Given this list of marker genes SOS1, RMI1, NHS, PICALM, IGF2BP3, ARMCX2, FOXA2, FIZ1, PRICKLE1, IRX5, UBC, SPRED2, SF1, ZFP91, SRSF3, NIPBL, JARID2, ACLY, OTX2, AP3D1, YWHAE, DDX6, KDM3A, PTMA, C2CD5, RBM39, GNG11, DHX15, BCL11A, TRA2B, XPO1, KANSL3, ACVR2A, RGL2, CEP95, POU2F1, MIRLET7BHG, TRIM27, DDX5, CCNA2, ADNP (activity dependent neuroprotector homeobox), E2F3, OGT, CRKL, CNOT3, ARMCX6, PPP2R2B, PAFAH1B1, CBX3, TDRD3, SMC3, EIF4G2, HNRNPA2B1, GLI1, PCF11 (NCBI Gene Id 51585), YY1AP1, PAK5, RGS17, AKAP8, RBM4, SP1, PTBP2, LIN54, SYT11, SLC32A1, DMTF1, ATP5MC2, ILF3, FAAH, ILF3-DT, CXXC5, SYNCRIP, HNRNPK, EIF4A2, FOXO3, WDR33, DAP3, GRHL3, AP1G1, SRRM1, ASCL1, NONO, MEIS2 (Meis homeobox 2), LRRC1, CRK, RBPJ, RFX1, DDX17, CSNK1A1, ADGRL3, TAF15, HEXIM2, TMEM187, KMT2E, GABPB2, ENSA, STAG2, CELF1, PHF21A, KDM2A, ZNF711, MAX, ZNF524, USP3, CTCF, HNRNPH1, NCAM1, LNPEP, here is a description of the gene set: Genes having at least one occurrence of the highly conserved motif M157 KCCGNSWTTT in the regions spanning 4 kb centered on their transcription starting sites. The motif does not match any known transcription factor binding site. Comprehensive identification of all functional elements encoded in the human genome is a fundamental need in biomedical research. Here, we present a comparative analysis of the human, mouse, rat and dog genomes to create a systematic catalogue of common regulatory motifs in promoters and 3' untranslated regions (3' UTRs). The promoter analysis yields 174 candidate motifs, including most previously known transcription-factor binding sites and 105 new motifs. The 3'-UTR analysis yields 106 motifs likely to be involved in post-transcriptional regulation. Nearly one-half are associated with microRNAs (miRNAs), leading to the discovery of many new miRNA genes and their likely target genes. Our results suggest that previous estimates of the number of human miRNA genes were low, and that miRNAs regulate at least 20% of human genes. The overall results provide a systematic view of gene regulation in the human, which will be refined as additional mammalian genomes become available. from publication Xie X, Lu J, Kulbokas EJ, Golub TR, Mootha V, Lindblad-Toh K, Lander ES, Kellis M (PMID 15735639) Human Gene Set: KCCGNSWTTT_UNKNOWN studied in species Homo sapiens